Given this list of marker genes GPR146, DDX42, GATA1, ACTG1, SULF2, FYCO1, EEIG1 (NCBI Gene Id 90676), C19orf38, GSAP, CTSO, CSRNP1, PJA1, SLC35B3, GFI1 (growth factor independent 1 transcriptional repressor, NCBI Gene Id 2672), SNRK, SDCBP, SUN2, PAG1, VPS13D, RASGRP1, ECM1, NAPG, PDE4B, CTSS, SOCS1, UQCC3, SIDT2, HYCC2, KIN, RC3H2, COL9A3, RNF213, ACAP1, LCP2, FNBP4, SEC23B, SARAF, ATP6AP2, PABIR1, PLEKHG2, CLEC16A, TAPBP, AKR1A1, NFATC2IP, MYH9, GPR162, FRMD4B, TTPAL, USP18, TDRP, PAK1, SLC39A1, COPA, DDX50, PTPN12, NR4A2, ZC3H11A, TRIM21, DOK2, IFI35, MSN, COG4, TRIB2, SLC25A14, KLF7, INPP5K, ACTR1A, LRCH3, STAP1, OSBPL9, EPSTI1, HPCAL1, PRKCQ, LARP7, TRIM25, KMT2E, PDE1B, SBNO2, ATOSA, ARSA, IQGAP1, IL6ST, GCC1, ASXL2, RUNDC1, ARHGAP30, SLC44A1, TUBA1A, STX5, DOCK8, NGDN, KHDC3L, LAMB3, WWP2, WIPF1, PEA15, AKAP13, DIP2B, MYCBP2, SCML4, SKAP2, TATDN2, CCNL1, C9orf85, IFI27L2, KIAA0040, LPAR6, E4F1, TUBB2B, RGS10, PHC1, MLEC (NCBI Gene Id 9761), SPAG9, RIPK2, SMPDL3A, CNTRL, MGAT4A, ACTN1, NPC2, PTPN18, IKZF1, PEAK1, XKRX, WDR26, PTTG1, ZDHHC5, RMND5B, BAZ2B, EGR2, RIOK3, ATF3, F2R, KLF2, ABCA7, PHKG2 (NCBI Gene Id 5261), LRP10, BIRC3, AAK1, MARCKSL1, LBR, ALPK3, RSU1, ARL6IP5, FLOT2, SYNPO, BTG2, EGR3, LGALS8, FBXO33, KBTBD11, GPR183, MPPE1, PTGER4, INPP1, UROD, SAMD9L (NCBI Gene Id 4827), CTSW, GPR171, ARHGAP15, LGALS7, LRP3, MATK, ZZEF1, TNIK, GIMAP4, GPSM3, MAN2B1, ZNF260, AFF1, MADD, FOSL2, IRF8, NEK8, APAF1, ZCCHC8, PLCG1, C2orf88, MON2, GBP7, FILIP1L, ZNRF1, ZBP1 (NCBI Gene Id 81030), CDKN2D, ATXN1L, PARP9, STAMBPL1, TTLL3, AP3D1, ASB11, RBM5, CERT1, PSME4, ARHGAP45, SDF2, GIT2, PARP14, RTP4, UGDH, COG8, PLD3, here is a description of the gene set: from publication Lund R, Aittokallio T, Nevalainen O, Lahesmaa R (PMID 14607935) Human Gene Set: GSE2770_TGFB_AND_IL4_VS_IL12_TREATED_ACT_CD4_TCELL_6H_UP Th1 and Th2 cells arise from a common precursor cell in response to triggering through the TCR and cytokine receptors for IL-12 or IL-4. This leads to activation of complex signaling pathways, which are not known in detail. Disturbances in the balance between type 1 and type 2 responses can lead to certain immune-mediated diseases. Thus, it is important to understand how Th1 and Th2 cells are generated. To clarify the mechanisms as to how IL-12 and IL-4 induce Th1 and Th2 differentiation and how TGF-beta can inhibit this process, we have used oligonucleotide arrays to examine the early polarization of Th1 and Th2 cells in the presence and absence of TGF-beta after 0, 2, 6 and 48 hours of polarization. Genes up-regulated in CD4 T cells activated by anti-CD3 and anti-CD28: TGFB1 and IL4 (6h) versus IL-12 (6h). species: Homo sapiens